Given this list of marker genes Snph, Mbd6, Rtl4, Igfbp5, Tac4, Cxcr5, Sec24c, Usp4, Spdef, Serf2, Dlk1, 2510039O18Rik, Snurf, Slc9a1, Tbc1d22b, P2rx3, Nuak2, Ccdc92b, Phf2, Tbc1d16, Scrt2, Mag, Anxa9, Tcf23, Dennd4a (NCBI Gene Id 319526), Tmem104, C5ar2, Parp6, Fbxl16 (F-box and leucine-rich repeat protein 16), Tanc2, Mapkapk2, Cacnb1 (calcium channel, voltage-dependent, beta 1 subunit), Lims2, H13, Hepacam, Dusp7, Ammecr1, Rab5b, Extl1, Pitpnm2, Pimreg, Strn4, Ephb3, Tirap, Wt1, Best3, Aifm3, Btrc, Sptbn4, Celf6, Anks4b, Gabpb2, Enc1, Fcer2a, Brpf3, Tbx4, Plppr2, 1700006A11Rik, Khnyn, Alx4, Ppp1r12c, Glyr1, Sfxn3, Gm14326, Tppp, Hipk1, Nptx1, Vegfa, Ttyh3, Rpp40, Rac3, Nynrin, Zbtb46, AW554918, Stk4, Lrrc8a, Rad9a, 1700102P08Rik, Slc25a20, Tmem86a, Tmem127, Stk36, Gbp9, Cfap44, Tgfbr2, Amer3, Hpcal4, Lhfpl4, Dlx2, Thbs3, Bmf, Lrch4, Fam120c, Slco2b1, Stc1, Anp32b, Fam53c, Rgma, Ndel1, Celf5, Kif26b, Cul3, Map3k10, Fbxl19, Dagla, Chpf, Per3, Dbndd1, Fscn1, Daam2, Pef1, Arrb1, Nacc1, Padi3, Btf3l4, Arid3b, Fam234b, Hspb3 (NCBI Gene Id 80555), Tbx2, Col5a1, Sox10, Scube1, Mdga1, Kif1a, B4galnt2, Smarcad1, Fam168a, Fam151b, Limk2, Atcay (NCBI Gene Id 208757), Pnma8b, Gp9, Ahnak, Ncald, Wscd2, Adpgk, Kremen1, Rnf44, Elovl7 (NCBI Gene Id 74559), Ak4, Efnb1, 1700025G04Rik, Oxsr1 (NCBI Gene Id 72172), Rarb, Hoxb5, Ntsr1, Spmip8, Rgs6, C2cd4c, Ldb1, Icmt, Bpifc, Ptprt, Gm14391, Col5a3, Kirrel1, Mtus1, Rbm14, Xylt2, Abl1, Cby1, Pdpk1, Mycl, Vps37d, Fam131b, Heyl, Atxn7l3, Vps16, Tspan18, Psmc4, Ky, Bend3 (NCBI Gene Id 331623), Gnao1, Ankrd33b, Drg2, Raly, Hnf1a, Rad23a, Trp53inp2, Zfp777, Rin3, Atn1, Myocd, Setdb1 (SET domain, bifurcated 1), Nxf1, Chrm1, Fbxo10, here is a description of the gene set: from publication Chen Y, Wang X (PMID 31504780) Genes predicted to be targets of miRBase v22 microRNA mmu_miR_6904_5p in miRDB v6.0 with MirTarget v4 prediction scores > 80 (high confidence targets). Mouse Gene Set: MIR_6904_5P species: Mus musculus